Given this list of marker genes FUT9, C9, RAB39A, WWP1, PEX3 (peroxisomal biogenesis factor 3), ZSWIM6, BCO2, DLAT, DRP2, GALNT13, ANKIB1, HLA-C, PPIAL4A, TSPYL6 (TSPY like 6), UBQLN3, CYP7B1, GABRR1, PPIAL4E (peptidylprolyl isomerase A like 4E), MKRN1, AOPEP, SDC1, CPEB2, PPP4R3A, TBC1D10B, COA6, ZNF510, DNAL1, RNF103 (NCBI Gene Id 7844), USP54, TMEM243, PPIAL4D, HMGXB4, NFIC, C1orf53, DUSP11, ANKH, PEG3, CREBRF, HLA-DPB1, CNNM4, TENM4, STAM, TEX30 (NCBI Gene Id 93081), FGF1, PML, TSC22D4, DPYSL3, LCP1, HBB, NPTX2, PPIAL4C, THUMPD1, FBXO32, PPIAL4F, PPIAL4G, SYNM, GRIK2, DCAF8L1, SLC15A5, GLIS3, DCLK1, SST, REEP5, TMEM72, TRPV3, CCR2, SRSF3, OSBPL7 (oxysterol binding protein like 7), RBM44, PDZD11, TAOK1, TMCC2, PFKFB2, ING5, THSD7A, MSL3, here is a description of the gene set: Genes predicted to be targets of miRBase v22 microRNA hsa-miR-6822-5p in miRDB v6.0 with MirTarget v4 prediction scores > 80 (high confidence targets). Human Gene Set: MIR6822_5P from publication Chen Y, Wang X (PMID 31504780) studied in species Homo sapiens